Given this list of marker genes Aldh1a2, Aldh1a3, Rest, Pdxp (pyridoxal (pyridoxine, vitamin B6) phosphatase), Rpe65, Bmp6, Cyp1b1, Hyi, Pnpo, Gapdh, Dkk3, Hoga1, Dhrs4, Glo1, Agxt2, Grhpr, Tkfc, Tpi1, Shpk, Aldh3b2, Mgat4a, Gpd1, Dab2, Mdh2, Scnn1b, Cacna1h, Kcnma1, Slc25a10, Aldh3b3 (NCBI Gene Id 73458), Idh2, Pgam1, Rdh13, Hagh, Tkt, Aldh3a2, Cyp11b2, Akr1c18 (NCBI Gene Id 105349), Rbp4, Aldh9a1, Rdh11, Mdh1 (malate dehydrogenase 1, NAD (soluble)), Esd, Aldh8a1, Khk, Sdr16c5, Pdxk, Akr1a1, Kdm3a, Adh4, Aldob, Bmp2 (NCBI Gene Id 98992), Bco2, Park7, Pnkd, Pgk1 (phosphoglycerate kinase 1), Pck1, Ednrb, Aldoa, Eno1, Agxt, Clcn2, Aldh3a1, Abca4, Bco1, Taldo1, Gatd1 (NCBI Gene Id 213350), Rpia, Pcx, Aldh3b1, Alpl, Cyp11b1, Wnt4, Adh5, Rpe, Haghl, Rdh10 (retinol dehydrogenase 10 (all-trans)), Aldh2, Idh1, Bmp5, here is a description of the gene set: The chemical reactions and pathways involving aldehydes, any organic compound with the formula R-CH=O, as carried out by individual cells. Mouse Gene Set: GOBP_ALDEHYDE_METABOLIC_PROCESS studied in species Mus musculus